The following is a description of a gene set: species: Homo sapiens Human Gene Set: REACTOME_TRANSPORT_OF_NUCLEOTIDE_SUGARS Transport of nucleotide sugars, and this is the list of marker genes: SLC35B2, SLC35D1, SLC35C1, SLC35A3, SLC35A1 (NCBI Gene Id 10559), SLC35D2, SLC35B4, SLC35B3, SLC35A2